The following is a description of a gene set: Human Gene Set: GOCC_PRP19_COMPLEX A protein complex consisting of Prp19 and associated proteins that is involved in the transition from the precatalytic spliceosome to the activated form that catalyzes step 1 of splicing, and which remains associated with the spliceosome through the second catalytic step. It is widely conserved, found in both yeast and mammals, though the exact composition varies. In S. cerevisiae, it contains Prp19p, Ntc20p, Snt309p, Isy1p, Syf2p, Cwc2p, Prp46p, Clf1p, Cef1p, and Syf1p. studied in species Homo sapiens, and this is the list of marker genes: POLR2A, PLRG1, BCAS2, RBM22, U2AF2, PRPF19, CDC5L, ISY1, CTNNBL1, SYF2, XAB2, HSPA8, CWC15, CRNKL1